Given this list of marker genes MGAT5B, SLC35A1, DAG1, POMK, LARGE1, SLC35A4, CHST10, POMGNT2, FKRP, POMGNT1, POMT2, RXYLT1, B3GALNT2, LARGE2, CRPPA, B4GAT1, FKTN, POMT1, here is a description of the gene set: Dystroglycan, encoded by the gene DAG1, can be cleaved into two proteins, alpha-DAG1 (chain 30-653) and beta-DAG1 (chain 654-895). Alpha-dystroglycan (here designated as DAG1(30-653)) is a cell surface protein that plays an important role in the assembly of the extracellular matrix in muscle, brain, and peripheral nerves by linking the basal lamina to cytoskeletal proteins. Alpha-DAG1(30-653) binds with high affinity to the extracellular matrix component laminin, and the intracellular domain of beta-DAG1(654-895) binds to the cytoskeletal protein dystrophin. Glycosylation is essential for DAG1(30-653) function. DAG1(30-653) is the best characterized O-mannosylated mammalian protein. O-mannose glycans are initiated on DAG1 by the covalent attachment of mannose to serine and threonine residues via an alpha-linkage. Extended O-mannose glycans divide into three categories based on known GlcNAc residue extensions of the initiating mannose (cores M1−M3) (Praissman & Wells 2014; Endo, 2019). The biosynthesis of the three categories are described here. We arbitrarily chose Thr-423, -481 and -367 for these modifications (see Tran et al., 2012 for justification). The M1, M2, and M3 reactions, that run in parallel in the cell, are listed here in a single linear order with their intermediates for display purposes.<br><br>Defects in the biosynthesis of O-mannose glycans can result in protein hypoglycosylation, compromising tissue structure and robustness. These hypoglycosylation defects are implicated in interaction-based pathologies, including congenital muscular dystrophies (CMDs) and cancers. studied in species Homo sapiens Reactome Pathway: DAG1 glycosylations part of: O-linked glycosylation